The following is a description of a gene set: species: Homo sapiens part of: SARS-CoV-1 Infection Reactome Pathway: SARS-CoV-1 Genome Replication and Transcription Using the genomic RNA as a template, the coronavirus replicase synthesizes full-length negative-sense antigenome, which in turn serves as a template for the synthesis of new genomic RNA. The polymerase can also switch template during discontinuous transcription of the genome at specific sites called transcription-regulated sequences, thereby producing a 5'-nested set of negative-sense sgRNAs, which are used as templates for the synthesis of a 3'-nested set of positive-sense sgRNAs. Although genome replication/transcription is mainly mediated by the viral replicase and confines in the replication-transcription complex (RTC), the involvement of various additional viral and host factors has been implicated. For instance, coronavirus N protein is known to serve as an RNA chaperone and facilitate template switching. Importantly, the N protein of SARS-CoV-1 and mouse hepatitis virus (MHV-JHM) is also phosphorylated by the host glycogen synthase kinase 3 (GSK3), and inhibition of GSK3 was shown to inhibit viral replication in Vero E6 cells infected with SARS-CoV-1. Additionally, GSK3-mediated phosphorylation of the MHV-JHM N protein recruited an RNA-binding protein DEAD-box helicase 1 (DDX1), which facilitates template read-through, favoring the synthesis of genomic RNA and longer sgRNAs. Another RNA-binding protein called heterogeneous nuclear ribonucleoprotein A1 (hnRNPA1) can also bind tightly to SARS-CoV N protein and potentially regulate viral RNA synthesis. Host RNA-binding proteins could also bind directly to untranslated regions (UTRs) of the coronavirus genome to modulate replication/transcription, such as zinc finger CCHC-type and RNA-binding motif 1 (ZCRB1) binding to the 5-UTR of IBV, mitochondrial aconitase binding to the 3' UTR of MHV, and poly(A)-binding protein (PABP) to the poly(A) tail of bovine coronavirus. For review, please refer to Snijder et al. 2016 and Fung and Liu 2019., and this is the list of marker genes: 1a, SARS coronavirus, complete genome, VHL, RB1, DDX5, N, rep, ZCRB1